The following is a description of a gene set: SEMA3A-Plexin repulsion signaling by inhibiting Integrin adhesion species: Mus musculus Mouse Gene Set: REACTOME_SEMA3A_PLEXIN_REPULSION_SIGNALING_BY_INHIBITING_INTEGRIN_ADHESION, and this is the list of marker genes: Farp2, Plxna2, Tln1, Plxna1, Plxna3, Fyn, Nrp1, Plxna4, Pip5k1c (NCBI Gene Id 18717)